The following is a description of a gene set: part of: Neurotoxicity of clostridium toxins Reactome Pathway: Toxicity of tetanus toxin (tetX) studied in species Homo sapiens Tetanus toxin (tetX, also known as TeNT), a disulfide-bonded heavy chain (HC) - light chain (LC) dimer, is secreted from bacteria growing in an infected wound directly into the circulation. Circulating toxin molecules associate with gangliosides at a synapse of a target neuron. The toxin is taken up into clathrin-coated vesicles that reach the neuron cell body by retrograde transport and then possibly other neurons before undergoing acidification. Vesicle acidification causes a conformational change in the toxin, allowing its HC part to function as a channel through which its LC part is extruded into the neuronal cytosol. Cleavage of the HC - LC disulfide bond releases the LC into the cytosol, where it functions as a zinc metalloprotease to cleave vesicle-associated membrane protein 2 (VAMP2), thereby blocking synaptic vesicle exocytosis., and this is the list of marker genes: VAMP2, tetX